Given this list of marker genes Bmpr1a, Fendrr, Nodal, Shh, Foxf1, Dand5, Fgfr1, Taf10, Cited2, Smad2, Tead2, Smo, Yap1, Tead1, Zic2, Mesp1, here is a description of the gene set: species: Mus musculus The process whose specific outcome is the progression of the lateral mesoderm over time, from its formation to the mature structure. Mouse Gene Set: GOBP_LATERAL_MESODERM_DEVELOPMENT